The following is a description of a gene set: An abnormally increased proportion of nuclei of sarcomeres with an internal localization. Individual muscle fibers are syncytia, formed by embryonic fusion of many myoblasts or later, myosatellite cells. Each muscle fiber contains many nuclei, peripherally positioned immediately adjacent to the sarcolemmal membrane. In healthy muscle only 3-5% of fibers contain nuclei that are located internally, within the cell, but many disease processes lead to internal nuclei. Human Gene Set: HP_INTERNALLY_NUCLEATED_SKELETAL_MUSCLE_FIBERS species: Homo sapiens Internally nucleated skeletal muscle fibers, and this is the list of marker genes: ACTN2, TTN, ADSS1, NOTCH2NLC, ANO5, RYR1, SQSTM1, LAMA2